The following is a description of a gene set: species: Mus musculus Mouse Gene Set: REACTOME_RHOC_GTPASE_CYCLE RHOC GTPase cycle, and this is the list of marker genes: Rtkn, Akap13, Pkn3, Arhgap5, Diaph1, Arhgef10l, Anln, Arhgdia, C1qbp, Jup, Fmnl3, Mcam, Myo9b, Rock2, Tjp2, Tfrc, Abr, Dlc1, Arhgap35, Arhgap18 (NCBI Gene Id 73910), Cavin1, Prex1, Daam1, Lman1, Iqgap1, Vangl1, Arhgap39, Arhgap21, Fmnl2, Racgap1, Erbin, Pkn1, Flot1, Mcf2, Arhgef11, Flot2, Arhgef28, Depdc1b, Pkn2, Arhgef5, Arhgef1, Acbd5, Arhgap26, Abcd3, Arhgef10, Vamp3, Mcf2l, Bcr, Lbr, Diaph3, Stard13, Vapb, Stom, Vav2, Pik3r1, Rhoa, Arhgef17, Cav1, Stx5a, Arhgap1, Stk10, Ophn1 (NCBI Gene Id 94190), Arhgap32, Rhoc, Maco1, Rock1, Arhgef25, Slk, Iqgap3, Arhgef12